Given this list of marker genes RPGRIP1, CCND3, ARFGAP3, CEP250, CRYBG1, ANO6, SH3BP1 (SH3 domain binding protein 1), ASB2, PRKRA, ADAM19, CASP7, STK3, IL7R, LGALS1, CTNNA1, CAMKK2, BCL2L1, RSPH1 (NCBI Gene Id 89765), STX2 (syntaxin 2), BRDT, TSPAN2, PHKA1, ARHGAP21, SLC37A1, CTDSPL (NCBI Gene Id 10217), CSRP1, TRAPPC9, CUL7, NFKBIE, PBX2, LASP1 (NCBI Gene Id 3927), PSTPIP2, PPP1R3E, LXN, MTCH1, GSN, PPP1R16B, here is a description of the gene set: from publication Boylan KL, Gosse MA, Staggs SE, Janz S, Grindle S, Kansas GS, Van Ness BG (PMID 17483317) Human Gene Set: BOYLAN_MULTIPLE_MYELOMA_D_CLUSTER_DN Genes from cluster 4: down-regulated in group D of tumors arising from overexpression of BCL2L1 and MYC in plasma cells. Multiple myeloma is an incurable plasma cell malignancy for which existing animal models are limited. We have previously shown that the targeted expression of the transgenes c-Myc and Bcl-X(L) in murine plasma cells produces malignancy that displays features of human myeloma, such as localization of tumor cells to the bone marrow and lytic bone lesions. We have isolated and characterized in vitro cultures and adoptive transfers of tumors from Bcl-xl/Myc transgenic mice. Tumors have a plasmablastic morphology and variable expression of CD138, CD45, CD38, and CD19. Spectral karyotyping analysis of metaphase chromosomes from primary tumor cell cultures shows that the Bcl-xl/Myc tumors contain a variety of chromosomal abnormalities, including trisomies, translocations, and deletions. The most frequently aberrant chromosomes are 12 and 16. Three sites for recurring translocations were also identified on chromosomes 4D, 12F, and 16C. Gene expression profiling was used to identify differences in gene expression between tumor cells and normal plasma cells (NPC) and to cluster the tumors into two groups (tumor groups C and D), with distinct gene expression profiles. Four hundred and ninety-five genes were significantly different between both tumor groups and NPCs, whereas genes were uniquely different from NPCs in tumor group C and genes were uniquely different from NPCs in tumor group D. Similar to human myeloma, the cyclin D genes are differentially dysregulated in the mouse tumor groups. These data suggest the Bcl-xl/Myc tumors are similar to a subset of plasmablastic human myelomas and provide insight into the specific genes and pathways underlying the human disease. species: Mus musculus